The following is a description of a gene set: Human Gene Set: WP_ALZHEIMERS_DISEASE_AND_MIRNA_EFFECTS Alzheimer's disease and miRNA effects studied in species Homo sapiens, and this is the list of marker genes: PIK3C3, MAPK9, MIR708, IL6, NOX1, TNFRSF1A, BECN2, SLC25A5, TUBA8, MIR377, PPP3CB, TUBA4A, ATP2A2, ADRM1, RB1CC1, MIR138-1, WNT11, MIR132, TUBB4A, BACE1, MIR135A1, PSMA6, CAPN2, WNT6, CALML3, PPP3CC, CHRNA7, MIR124-3, FZD7, DKK1, MIR410, MIR138-2, MIR769 (NCBI Gene Id 768217), DKK2, PSEN1, PSMB7, ATP2A1, CSNK1E (NCBI Gene Id 1454), IKBKB, PSMA2, PIK3CA, MIR125A, MIR887, XBP1, TUBB8, FZD10, BECN1, APP, ATF6, KIF5A, SEM1 (SEM1 26S proteasome subunit), PIK3R2, MAPK8, AXIN1, TUBA1C, CSNK2A3, MIR760, FRAT1, APOE, CASP8, MME, CASP3, SLC25A6, CYCS, MIR139, BAD, CSNK2B, NRAS, PPP3R2, NOX4, TUBA1B (NCBI Gene Id 88851), WNT10A, NOS1, FZD2, AKT2, MIR181B2, CSNK2A1, ATG2B, CACNA1S, PSMB3, CSF1, ATG2A, MIR33B, PSMA7, TUBB2A, WNT1, RYR3, MIR30C2, KRAS, ATG13, MIR95, WNT16, HRAS, PSMD9, KLC4, MAP3K5, MIR127, RTN3, TUBA3D, MAPT, MIR9-1, MIR181B1, CALML4, MAP2K1, CALM1 (calmodulin 1), MIR1307 (microRNA 1307), MIR431, PSMC2, MIR381, ATG14, MIR124-2, AKT1, SLC25A31, PTGS2, MIR1285-2, FADD, PSMD4 (NCBI Gene Id 5710), TUBB4B, MIR29A, MIR323A, CHUK, RELA, VDAC2, MIR181D, CSNK1A1L, INSR, GAPDH, PSMD3, INS, CTNNB1, MIR671, WNT3A, PSMB1 (proteasome 20S subunit beta 1), IRS4, PSMA5, GPR83 (NCBI Gene Id 95200), TUBB2B, APH1B, PLCB3, TRAF2, KIF5C, PSMC3 (proteasome 26S subunit, ATPase 3), PSMB5, ADAM17, GRIN2B, NAE1, MCU, PSMB6, MIR488, CDK5, NFKB1, MIR9-2, PSMC5, MIR124-1, PSEN2, FZD1 (NCBI Gene Id 8321), ERN1, FAS, KIF5B (NCBI Gene Id 3830), CSNK2A2, IDE, PSMD1, MIR34C, PSMD2, MIR34B, WIPI2, MIR181A1, ATF4, GRIN2A, FZD8, SNCA, TUBB3, MIR219A2, ITPR1, DDIT3, KLC2, MIR3176, ULK2, DVL3, PSMB2, DVL2, DVL1, GRIN1, MAPK1, VDAC1, MIR199B, TUBB1, MIR329-2, CAPN1, CALML5, IRS1, MIR874, MIR101-1, PIK3CD, EIF2S1, ULK1, GNAQ (NCBI Gene Id 2776), MIR10A, PPID, TUBAL3, MAPK10, CALM3 (calmodulin 3), RTN4, TUBA3E, IL1B, GRIN2C, CACNA1F, PSMD13, EIF2AK3, PLCB2, PPIF, PSMD14, MAPK3, ITPR3, VDAC3, PSMC1, APBB1, MIR134, WNT3, BRAF, CACNA1D, MIR3200, PIK3R4, PIK3CB, AKT3, TUBB6 (NCBI Gene Id 84617), MIR375, CSNK1A1, MAP2K2, LRP5, MIR29C, PIK3R1, AXIN2, MIR218-1, APH1A (NCBI Gene Id 82089), PSMC4, MIR136, ARAF, IRS2, PSMB4, KLC1, MIR326, SFRP4, LRP6, FRAT2, PSMD8, EIF2AK2, MIR21, NCSTN, KLC3, MIR125B1, TNF, MIR873, WNT4, APC2, MIR135A2, FZD6, AMBRA1, MIR329-1, ATP2A3, MIR182, PSMD7, NOS2, ITPR2, PSMA1, MIR129-1, TUBB, LRP1, RAF1, WIPI1, TUBA3C, MIR433, LPL (NCBI Gene Id 4023), CYBB, NRBF2, MIR181A2, WNT2B, PSMC6, WNT5B, BID, WNT2, DKK4, MAP2K7, PPP3R1 (protein phosphatase 3 regulatory subunit B, alpha), PSMD6, MIR495, ADAM10 (ADAM metallopeptidase domain 10), MIR29B1, PPP3CA, WNT5A, APAF1 (apoptotic peptidase activating factor 1), AGER, WNT7A, CDK5R1, CALML6, WNT10B, MIR184, PSMA8, CALM2, PLCB4, CASP9, CASP7, MIR598, FZD3, MIR218-2, PSMA4, PLCB1, IL1A, PIK3R3, WNT7B, PSENEN, CACNA1C, APC, PSMA3, FZD9 (frizzled class receptor 9), GSK3B, ATG101, MIR129-2, SLC25A4, HSD17B10, FZD5, MTOR, MIR9-3, TUBA1A, GRIN2D, PSMD12